The following is a description of a gene set: The aim of this study was to identify genes regulated by IL-12, IL-18 and IFN-alpha during early differentiation of human Th1 cells studied in species Homo sapiens Genes down-regulated in the activated CD4 T cells (48h): control versus IL-12 and IL18. from publication Filén S, Ylikoski E, Tripathi S, West A, Björkman M, Nyström J, Ahlfors H, Coffey E, Rao KV, Rasool O, Lahesmaa R (PMID 20304822) Human Gene Set: GSE20198_UNTREATED_VS_IL12_IL18_TREATED_ACT_CD4_TCELL_DN, and this is the list of marker genes: ZNF493, HAX1, C9orf40, LRRC72, VAMP3, PRXL2A, ELF2, NRGN, AARS2, DMAC2L, ICOSLG, PAM, KCP, AFG1L (NCBI Gene Id 246269), MVB12A, B3GNT3, PTPA, NEK3, ERGIC3, THOC1, EMC3, CDKN2C, SCRN3, GRN, SLC9A9, KCNK6, NGDN, C1QBP, COX17, TRPV1, UNC45A, DCTD, MYBPC3, PPP2R1B, RABL3, HDAC1, COX6C, MED20, SRSF6, MTERF1, GRWD1, RNF181, NUP43, MYO7B (myosin VIIB), CCR7, GFI1, MRPL39, MAT2A, HAUS3, GARIN1B (golgi associated RAB2 interactor 1B), CCNG1, SLC45A3, ACD, VKORC1, MARVELD2, MAK16, SLC5A1, GNL1, TRIM21, EMC2 (NCBI Gene Id 9694), WDR76 (NCBI Gene Id 79968), C1orf210, AGBL4, UTP15 (NCBI Gene Id 84135), UBR5, NDUFA7, UBE2N, CREG2, USP39, IL25, FMNL3, SAMM50, RGS16, NHP2, ALG14, SH3BP2, ICOS (NCBI Gene Id 29851), PDZD11, VCPKMT, ENSA, WDR77 (WD repeat domain 77), CCDC6, YIF1B, FASTKD2, TMEM160, DDX5, FYTTD1, SAP30, VMA21, GMPPA, NTAQ1, FAM171B, MAFF, POP7, NBEA, TAF13, DNAAF9 (NCBI Gene Id 348549), ALDOC, LCMT1, SUB1, STX6, ATF4, SMARCA5, PIAS2, AKAP12, LY96, PNPLA6, COX11, WRAP53, SNHG8, ZMAT2, CLEC4G, NF1, GEM, LINC00511, NR1H2, IGFLR1, TELO2, MRPL15 (NCBI Gene Id 65001), GLIPR1, IRF9, DNAJC12, KLF6, MINDY3, KPTN, ZNF687, SELENOS, SLC7A1, NDUFS4, FAM50A, MYCBP, UTP4, PARP3, EARS2, FOS, SHISAL1, MRPL46, DNAJC4, SERF2, CTRL, KRT2, ZNF446, MAN1A2, TCTN3, CLBA1, CITED2, STRN4, FGF13, ZBTB9, ARMC5, ERI2, NOP58, MRPL42, PXDC1, ZC2HC1A, ELOVL5, CERS6, ZEB2, REXO4, SEC11A, PLPP5, BASP1, PLEKHH1, ZBTB3, CAAP1, ADCK1, MIR22HG, JMJD4, SPSB2, TMEM241, ORMDL2, GAS1, ABHD1, SKIC8, FCF1, NSUN4, KCNC1, ABCB1, MCU, NSDHL, DNAJB4, FASTKD5, GNL3, EHD1, PIGO, RAD51C, NSA2, NLK, TRIM27, NFAT5, ZCCHC17, WDR54, SREBF2, ARL6IP1, DCUN1D5, RAB5C, ERGIC2, KRTCAP2, COX19, CCT7